The following is a description of a gene set: species: Homo sapiens The interferon-producing plasmacytoid dendritic cells (PDC) share common progenitors with antigen-presenting classical dendritic cells (cDC), yet they possess distinct morphology and molecular features resembling those of lymphocytes. It is unclear whether the unique cell fate of PDC is actively maintained in the steady state. We report that the deletion of transcription factor E2-2 from mature peripheral PDC caused their spontaneous differentiation into cells with cDC properties. This included the loss of PDC markers, increase in MHC class II expression and T cell priming capacity, acquisition of dendritic morphology and induction of cDC signature genes. Genome-wide chromatin immunoprecipitation revealed direct binding of E2-2 to key PDC-specific and lymphoid genes, as well as to certain genes enriched in cDC. Thus, E2-2 actively maintains the cell fate of mature PDC and opposes the “default” cDC fate, in part through direct regulation of lineage-specific gene expression programs. Human Gene Set: GSE24726_WT_VS_E2_2_KO_PDC_DAY6_POST_DELETION_UP from publication Ghosh HS, Cisse B, Bunin A, Lewis KL, Reizis B (PMID 21145760) Genes up-regulated in plasmacytoid dendritic cells (6 days after knockout): wildtype versus TCF4 knockout., and this is the list of marker genes: ARHGAP39, NHSL3, PITHD1 (NCBI Gene Id 96276), PKIG, HNMT, SLC27A1, GNA13, DLGAP5, ICOSLG, CMSS1, NRP1, RPA1, LANCL1, MRPL35, WLS, RBL1, MPG, COL14A1, OCIAD2, CEBPA, HPRT1, PSMB2, NOL7, FEN1, UTP14A, MED20, AURKB, MED7, SURF1, ARL2BP, HOPX (HOP homeobox), RNF167, CIR1, ATP6V1C1, CORO1A, TCTN3, MSRB2, POGLUT2, UHRF2, MTMR10, C2CD5, GPR19 (G protein-coupled receptor 19), PRR11, SH3BP5L, SETD7, GPX3, MAPRE2, EOLA1, AMZ2, CCR2, SH3PXD2A, CDK2AP1, NAPSA, EIF4B, RBM48, EIF3K, CDT1, TCEANC2, MTMR14, ZNF583, CCDC90B, SLC25A13, LRWD1, TBCC, GNPDA2, PIGP, COPS2, MFNG, CNOT6L, NAT8L, RBFA (NCBI Gene Id 79863), PRPS2, FUCA1, PPIH, CCT2, TBRG1, MCM6, ST3GAL5, PUS10, WEE1, DZIP3, RPL18, NME2, RTRAF, MRPL24, ZFYVE1 (NCBI Gene Id 57694), AK3, DYRK1A, PRUNE2, HINT2, FXR1, FBXO32, CENPH, PRXL2C, IDH3G, PANK1, TMX4, ZNF12, MYO1E, COX19, ATF6 (NCBI Gene Id 22926), USP27X, TPGS1 (NCBI Gene Id 91978), ZNF251, WDR81, SPC24, TRPV2, GMNN, EIF3E (eukaryotic translation initiation factor 3 subunit E), POLB, EXTL3, HMG20A, RPL18A, NDUFB11, LIN9, RPS4X, RRAGC, EXOC3, SP1, NUDT13, HP1BP3, HYLS1, TBC1D31, MYLIP, CENPK (NCBI Gene Id 64105), GTSE1, FOXN3, PAN2, GPR34, BTK, CAPN2, CRLF3, SKIL (SKI like proto-oncogene), PCYT1A, CYB561A3, ATG16L2 (NCBI Gene Id 89849), EFCAB11, ARHGAP17 (Rho GTPase activating protein 17), PLEKHM1, TEC, CNTRL, PRIM2, N4BP2L1, INTS3, AP4B1 (NCBI Gene Id 10717), DOCK8, SLC25A17, FMNL3, WDHD1, NUDT5, RPL35, MRE11, GCC2, AP1G2, TCF4, UBN1, DARS2, NANS, DRG1, DGKZ, LEPROTL1, UQCC3, NPAT, NDUFAF1, TRIM28, RFC5, ZNF124 (zinc finger protein 124), WDR12, ASNSD1, SELENOM, ABCF3, METTL27, ERCC6L, SENP2, IFNLR1, PALD1, CCDC77, JADE3, SHCBP1, RSL24D1 (ribosomal L24 domain containing 1), RFX7, NLRC3, BRMS1 (BRMS1 transcriptional repressor and anoikis regulator), TIMM21, NIPAL3, BLOC1S5, DMAC1 (distal membrane arm assembly component 1), RIT1, ETFDH, WBP1, PPP3CA, SF3B2, B3GALNT1, UBE2T, FLVCR1, TSEN2, GPSM2, MIR99AHG, TMT1A, MTPAP